Given this list of marker genes Emc10, Vps72, Nasp, Asf1a, Emc6, Timm9, Emc7, Prdm12, Pex19 (peroxisomal biogenesis factor 19), Mtch2, Aplf, Clu, Jdp2 (Jun dimerization protein 2), Ipo9, Emc9 (NCBI Gene Id 85308), Emc8, Pwp1, Bag6, Emc4, Cox18, Get3, Wrap53, Hira, Mtch1, Spty2d1, Ptma, Wfs1, Emc2, Hirip3, Asf1b, Myd88, Emc1, Dusp16, Timm10, Emc3, Nap1l1, Anp32e, Pex5, Mmgt1, Get4, Oxa1l, here is a description of the gene set: Mouse Gene Set: GOMF_PROTEIN_CARRIER_CHAPERONE Binding to and carrying a protein between two different cellular components by moving along with the target protein. species: Mus musculus